The following is a description of a gene set: Mouse Gene Set: chr9A3 studied in species Mus musculus, and this is the list of marker genes: Or7g33, 1700084C06Rik, Gm18227, Gm16754 (NCBI Gene Id 100503569), Rdh8, Keap1, Pde4a, Gm6607, Zfp810, Gm29761, Tmem205, S1pr5 (sphingosine-1-phosphate receptor 5), Rp9, Or7e166, Mir7084, Zfp653, Gm10182, Gm23316 (predicted gene, 23316), Cdkn2d, Cdc37, Dock6, Gm16165, Fdx2, Or7g34, Gm2976 (predicted gene 2976), Or7d12-ps1, 4921534A09Rik, Bbs9, Slc44a2, Zfp266, Or7h8, Gm24067, Or7e178, Prkcsh, Angptl6, Qtrt1, Fbxl12, Spc24, Ilf3, Gm36198, Zfp426, Shfl, Kank2, Mir7083, Gm16845, Tyk2, Odad3 (NCBI Gene Id 77609), Mir199a-1, Zfp26, Angptl8, Zfp599 (NCBI Gene Id 235048), Elof1, Zfp872, Fbxl12os, Pin1, Or8b12i (NCBI Gene Id 57251), AB124611, S1pr2, Gm39307, Mir1900, Ecsit, Rpl15-ps3, Icam4, Gm25425, Gm3028, Gm7808, Tmed1, Epor, Zglp1, Dnm2, Gm16853, Or7d9, Ccdc159, Matcap2, Eif3g, Timm29, Gm23008, Rab3d, Or7d13-ps1 (NCBI Gene Id 404437), Smarca4, Mir7082, Zfp846, Ppan, Acp5, Or7e171-ps1, Icam1, Or7d11, Pigyl, 1810064F22Rik, Or7d10, Cnn1, Bmper, Anln, Gm6581, Carm1, 6530413G14Rik, Ubl5, Gm7769, Yipf2, Or7e175, Gm18225, Zfp809, Gm39302, Gm3011, Or7e176, Raver1, Gm18228, Plppr2, Kri1, Mir7081, Mrpl4, Ap1m2, Or7e170, Or7e167-ps1, Gm38431, Olfr852-ps1, Col5a3, Or7e168, Icam5, Zfp317, Or7g35, Npsr1, Or7e173, Ldlr, Mir1946b, Elavl3, Gm46142, Zfp560, Or7e165, Gm7904, Or7e169, Gm26592, Dnmt1, Or7e177, Olfr865-ps1 (olfactory receptor 865, pseudogene 1), Olfm2, Swsap1, Rgl3, Atg4d, Gm26511, Or7e174, Or7e172-ps1